Given this list of marker genes GDNF, HOXB1, SEMA3A, TBX1, TFAP2A, NRP2, EGR2, PLXNA3, SEMA3F, PHOX2A, PLXNA4, PHOX2B, NRP1, HOXB2, SIX1, NAV2, ADARB1, HES1, ACKR3, here is a description of the gene set: The process whose specific outcome is the progression of the parasympathetic nervous system over time, from its formation to the mature structure. The parasympathetic nervous system is one of the two divisions of the vertebrate autonomic nervous system. Parasympathetic nerves emerge cranially as pre ganglionic fibers from oculomotor, facial, glossopharyngeal and vagus and from the sacral region of the spinal cord. Most neurons are cholinergic and responses are mediated by muscarinic receptors. The parasympathetic system innervates, for example: salivary glands, thoracic and abdominal viscera, bladder and genitalia. studied in species Homo sapiens Human Gene Set: GOBP_PARASYMPATHETIC_NERVOUS_SYSTEM_DEVELOPMENT